The following is a description of a gene set: A type of extracellular matrix found in interstitial connective tissue, characterized by the presence of fibronectins, proteoglycans, and types I, III, V, VI, VII and XII collagens. species: Homo sapiens Human Gene Set: GOCC_INTERSTITIAL_MATRIX, and this is the list of marker genes: EGFLAM, VWC2, TNC, VIT, VWA1, ADAMTSL4, NAV2, COL14A1, KAZALD1, CCDC80, ECM2